Given this list of marker genes Wnt3a, Ifrd1, Wnt5a, Wnt3, Rnf6, Actr3, Sema3a, Map2, Rtn4 (NCBI Gene Id 68585), Plxna3, Ptprs, Tnr, Hdac6, Fstl4, Sema4f, Cdkl3, Sema3g, Ntn1, Ryk, Trim46, Ccr5, Sema3f, Nrp1, Rtn4r, Mt3, Ttc3, Sema6d, Arhgap4, Cdh1, Slit2, Slit1, Sema6c, Sema5a, D130043K22Rik (RIKEN cDNA D130043K22 gene), Dip2b, Draxin, Mag (myelin-associated glycoprotein), Cdk5, here is a description of the gene set: Mouse Gene Set: GOBP_NEGATIVE_REGULATION_OF_AXON_EXTENSION Any process that stops, prevents, or reduces the frequency, rate or extent of axon outgrowth. species: Mus musculus